Given this list of marker genes MYL9 (myosin light chain 9), CDC42BPB, B9D1, KANSL1, FH, PIGA, FGF13, TBCK, CLCN3, GRIP1, ZBTB18, PI4KA, BNC2, here is a description of the gene set: studied in species Homo sapiens Human Gene Set: HP_ABNORMAL_FETAL_GENITOURINARY_SYSTEM_MORPHOLOGY Abnormal fetal genitourinary system morphology An anomalous structural finding of the fetal genitourinary system. Terms in this subhierarchy are restricted to findings that can only be observed in the prenatal period. Other HPO terms can also be used to describe fetal phenotypes.